The following is a description of a gene set: studied in species Homo sapiens Human Gene Set: GOBP_APPENDAGE_DEVELOPMENT The process whose specific outcome is the progression of an appendage over time, from its formation to the mature structure. An appendage is an organ or part that is attached to the trunk of an organism, such as a limb or a branch., and this is the list of marker genes: OSR1, HOXD9, SLC39A3, ITGA6, WNT3, ZNF141, HAND2 (heart and neural crest derivatives expressed 2), HOXC11, FGFR1, PBX1, FGF8, AFF3, ZNRF3, IHH, TWIST1, COMP, WNT5A, TGFB2, RUNX2, FGF9, TFAP2B, FBXW4, TULP3, NFIA, KAT2B, LARGE1, FREM2, CACNA1C, BAX, TFAP2A (NCBI Gene Id 95131), ASPH, SHOX2, HOXC10, PRICKLE1, WDR19, MKS1, FERMT2, ALDH1A2, FGF10, TBX3, NIPBL, HOXA11, SMAD4, GPC3, FGF4, KRT84, CHD7, ECE1, TMEM231, SLC7A11, RDH10, LNPK, NPR2, PTCH1, FRAS1, GLI3, RARA, SALL1, VPS54, SHH, INTU, PITX2, HOXA9, HOXA10, TBC1D32, MSX1, TBX2, WDPCP, LEF1, BPNT2, ARK2C, COL2A1, SEMA3C, HOXA13, B4GALNT1, NOTCH1, SP9 (NCBI Gene Id 100131390), MYCN, BMP4, FGFR2, GNA12, PCSK5, PIAS4, RAX, BMPR2, SOX9, TAF10, KDF1, MED1, IRF6, HDAC2, OSR2, CTNNB1, B9D1, SLC39A1, TP63, NOTCH2, GDF5 (NCBI Gene Id 8200), CIBAR1, IFT52, ZIC3, BMP7, TBX4, MED31, PRKAB1, NAGLU, EN1 (engrailed homeobox 1), WNT7A, DLX5, ATRX, COL3A1, MUSTN1, CRABP2, SCX, IFT140, RSPO4, IQCE, MAP3K20, KAT2A, DKK1, ITGB4, DYNC2H1, IFT172, KREMEN2, GALNT3, PBX2, PSEN1 (NCBI Gene Id 5663), TRAF3IP1 (NCBI Gene Id 26146), ZNF358, SPG21, MEOX2, SFRP2, FBN2, MEGF8, ERRFI1, ALX4, CYP26B1, RECK, KREMEN1 (NCBI Gene Id 83999), PLXNA2, GREM1, PRRX1, ALX3, C2CD3, MYH3, LRP4, TMEM107, ZNF219, MBNL1, PKDCC, LMBR1, RC3H2, GRHL2, BAK1, ACD, RPGRIP1L, BCL2L11, FOXN1, NOG (NCBI Gene Id 9241), RSPO2, EVX2, BMPR1A, CREBBP, IFT80, HOXD13, HDAC1, RARG, SP8, COL6A1, TTBK2, CHST11, TBX5, PITX1 (NCBI Gene Id 5307), SALL4, ZBTB16, BBS7, DLX6, MSX2, CPLANE2, HOXD12, SMOC1, MOSMO, HOXD10, LRP5, EXT1, FZD6, SKI, IFT122, B3GLCT, ALX1, RARB, HOXC13, FLVCR1, GJA5